Given this list of marker genes Laptm5, Pglyrp1, Slamf1, Lilrb4a, Il1rl1, Nlrp6, Pglyrp2, Zfp683, Pglyrp4, Gimap5, Nr1h4, Il10, Pdcd1lg2 (NCBI Gene Id 58205), Havcr2, Vsir, C1qbp, Prnp, Zc3h12a, Sh2d1b1, Il20rb, Ddit3, Cd96, Axl, Foxp3, Gimap3 (GTPase, IMAP family member 3), Il33, Cd276, Ifnb1, Hmgb1, Nod2, Rara, Il36rn (interleukin 36 receptor antagonist), Tnfsf4, Xcl1, Cd274, Gata3, Lgals9, Lilrb4b (leukocyte immunoglobulin-like receptor, subfamily B, member 4B), Tlr4, Gas6, Pglyrp3, Scgb1a1, Irgm1, here is a description of the gene set: Mouse Gene Set: GOBP_NEGATIVE_REGULATION_OF_TYPE_II_INTERFERON_PRODUCTION studied in species Mus musculus Any process that stops, prevents, or reduces the frequency, rate, or extent of interferon-gamma production. Interferon-gamma is also known as type II interferon.